Given this list of marker genes LAMTOR5, SLC38A9, LAMTOR4, LAMTOR1, LAMTOR3, LAMTOR2, here is a description of the gene set: Human Gene Set: GOCC_RAGULATOR_COMPLEX studied in species Homo sapiens A vacuolar membrane-anchored guanine nucleotide exchange factor (GEF) complex for the Rag GTPases (Gtr1-Gtr2 GTPase complex ) in TORC1 signaling pathway. In human, Ragulator is comprised of the membrane anchor subunit LAMTOR1 (Meh1p in S. cerevisiae, Lam1 in S. pombe), a GEF subunit LAMTOR2 ( Slm4 in S. cerevisiae, Lam2 in S. pombe ), LAMTOR3 (no S. cerevisiae ortholog identified, Lam3 in S. pombe), LAMTOR4 (no S. cerevisiae ortholog identified, Lam4 in S. pombe), and LAMTOR5 (no S. cerevisiae or S. pombe ortholog identified).